Given this list of marker genes XBP1, GCKR, KHK, LCN2, SREBF1 (NCBI Gene Id 6720), SLC26A6, PPARA, TNF, SLC2A5, here is a description of the gene set: Human Gene Set: GOBP_RESPONSE_TO_FRUCTOSE species: Homo sapiens Any process that results in a change in state or activity of a cell or an organism (in terms of movement, secretion, enzyme production, gene expression, etc.) as a result of a fructose stimulus.